The following is a description of a gene set: Reactome Pathway: RHO GTPases regulate CFTR trafficking part of: RHO GTPase Effectors studied in species Mus musculus This event has been computationally inferred from an event that has been demonstrated in another species.<p>The inference is based on the homology mapping from PANTHER. Briefly, reactions for which all involved PhysicalEntities (in input, output and catalyst) have a mapped orthologue/paralogue (for complexes at least 75% of components must have a mapping) are inferred to the other species. electronically inferred by orthology from the curated human pathway, and this is the list of marker genes: Gopc